The following is a description of a gene set: Human Gene Set: GOBP_RESPONSE_TO_OSCILLATORY_FLUID_SHEAR_STRESS species: Homo sapiens Any response to fluid shear stress where the fluid is moving across a solid surface with an oscillatory flow. Disturbed flow patterns at the arterial bifurcations and curvatures may cause endothelial dysfunction, which initiates atherosclerosis., and this is the list of marker genes: PTK2, PTPN1, PPP2CA, CAPN2, ABL1